The following is a description of a gene set: The pancreatic adenocarcinoma genome harbors multiple amplifications and deletions, pointing to the existence of numerous oncogenes and tumor suppressor genes driving the genesis and progression of this lethal cancer. Here, array comparative genomic hybridization on a cDNA microarray platform and informatics tools have been used to define the copy number alterations in a panel of 24 pancreatic adenocarcinoma cell lines and 13 primary tumor specimens. This high-resolution genomic analysis has identified all known regional gains and losses as well as many previously uncharacterized highly recurrent copy number alterations. A systematic prioritization scheme has selected 64 focal minimal common regions (MCRs) of recurrent copy number change. These MCRs possess a median size of 2.7 megabases (Mb), with 21 (33%) MCRs spanning 1 Mb or less (median of 0.33 Mb) and possessing an average of 15 annotated genes. Furthermore, complementary expression profile analysis of a significant fraction of the genes residing within these 64 prioritized MCRs has enabled the identification of a subset of candidates with statistically significant association between gene dosage and mRNA expression. Thus, the integration of DNA and RNA profiles provides a highly productive entry point for the discovery of genes involved in the pathogenesis of pancreatic adenocarcinoma. Human Gene Set: AGUIRRE_PANCREATIC_CANCER_COPY_NUMBER_UP species: Homo sapiens from publication Aguirre AJ, Brennan C, Bailey G, Sinha R, Feng B, Leo C, Zhang Y, Zhang J, Gans JD, Bardeesy N, Cauwels C, Cordon-Cardo C, Redston MS, DePinho RA, Chin L (PMID 15199222) Up-regulated genes whose expression correlates with copy number gains in pancreatic adenocarcinoma cell lines and primary tumor specimens., and this is the list of marker genes: BAG4, ZNF304, SARS2, ID1, INTS1, EML2, OPLAH (5-oxoprolinase, ATP-hydrolysing), SLC35B1, SYPL1, HEXIM2-AS1, DERL1, ZNF134, ANKRD40, KTN1, LRRC59, NPC1, TCFL5, ZNF331 (NCBI Gene Id 732358), DDHD2, MRPS12, ZNHIT1, NPAS3, CYRIB, PTOV1-AS2, SLC12A9, TNXA, PRKCH, MLX, PRMT1, TAF4, ZNF652, RNF6, RGP1, PCTP, EHD2, FCF1, SLC1A5, ATP6V0A1, EAPP, EPN1, BECN1, PON2, POLR1G, TBC1D31, CABYR, PPP1R13L, ICE1, RPL18, GID8, NDUFS6, SIRT2, CREB3, ATP5F1E, RPL13A, TRRAP, PTK2, EXOC5, RAB5C, PLEKHA4, MYL10, RNF38, NR1H2, DDT, HNRNPL, NPR2, MYC, ARHGAP35, ACTR10, FAM117A, LSM1, AOC2, OSBPL1A, NAPA (NCBI Gene Id 8775), ASH2L, GPER1, LUC7L3, ZNF444, PSMC3IP, AARSD1, PDCD6, ACLY, NME2, CNPY3, SLC25A13, HAS2, DUSP3, PAF1, RUVBL2, NTAQ1, G6PC3, ZC3H3, ASL, CMAS, CBLL1, MTAP, ZNF211, SPATA20, AP4S1, MPP3, SNX11 (sorting nexin 11), AP5M1, WDR3, NPEPPS, GRWD1, KDELR1, FUT1 (NCBI Gene Id 2523), SMARCE1, PNPO, WASHC5, CELA2B, SCFD1, PPP2R5D, DKKL1, PDK4, SYT5 (synaptotagmin 5), CASKIN2, MICALL2, MAPK1IP1L, TTF2, BAX, DOCK4, RPS9, ZNF573, EZH1, IRF3 (interferon regulatory factor 3), BMP4, NKIRAS2, GSTT1, WDHD1, SS18L1, CDC27, ZDHHC24, ARPC1B, NOSIP, NME1, TAF6, CEP72, FIS1 (fission, mitochondrial 1), SDHA, RPS21, EEF1D, DGAT1, EXOSC4, UPF3A, LHB, TMEM94, ZNF580, SDHAF3, HLF, BET1, PLOD3, CNOT3, FBXO34, LRRC37A, RPL27, TPD52L2, ATXN7L1, GIPR, LIG1, SNRNP70 (NCBI Gene Id 6625), HIF1A (hypoxia inducible factor 1 subunit alpha), SMURF1, TMEM8B, KRT10, RASA4 (NCBI Gene Id 10156), KAT7, PAK4, TSEN34, SNX6, LRRC37A4P, ZNF460, PHB1, SHARPIN, SNF8, RETREG3, EPN3, CYP3A5, PRKD2, RMC1, ARFRP1, CLTA, PARP4, ADGRA2, DPF1, BRF2, SLC52A2, PLEKHG3, KCTD7, GPATCH8, SPOP, NUCB1, ZFTRAF1, OR7E12P, UCKL1, PDK2, ACSF2, DMPK, EIF3K, NUP62, YTHDF1, SAMD4A, FBXO17, PMS2P8 (PMS1 homolog 2, mismatch repair system component pseudogene 8), UTP18, PVT1, SNAPC1, ORAI2, GFUS, SPAG9, RSAD1, PRPF6, VPS28, AP4M1, ZGPAT, GARS1, COA3, TLN1, ANXA13, PSMD8, STAT5B, RABGEF1 (RAB guanine nucleotide exchange factor 1), ZNF787, KPNB1-DT, SLC39A4, OPA3, COX11, ATP5MC1, SEM1, CRCP, GRN, LPCAT1, CASD1 (CAS1 domain containing 1), MRPL13, ZNF264, SNRPD2, RCN3, PCNX4, UBE2Z, NFKBIB, PSMA7, DLD, LMTK2, NSF, CPSF1, ZNF419, GSDMD, ZKSCAN5, TMEM248, HGH1, DBP, TUG1, KPNB1, TAF2, CYC1, ZNF623, ASNS, MAD1L1, RIOK3, MBOAT7, NDRG1, NMT1, TMUB2, OSBPL2, MYL6, GYS1, SCRIB, ZBTB1, GNB2, RASA4B, MAP4K1, ARL17A, BRD9, NUDC, MTMR6, ZNF146, AP2S1, CDKN2A, ARPC1A, SPAG8, THEM6, NBR1, KLK13, PPP1R3D, XYLT2, DLGAP5, PRELID3B, TPM2, SLC26A4, NUBPL, NSD3, LAMA5, STRN4, MPP2, CBX1, MAFK, RNF139, GPAA1, ARHGAP5, PON3, C5AR1, U2AF2, PSME3, SLC66A3, EXOC3